The following is a description of a gene set: species: Mus musculus Mouse Gene Set: GOBP_VENTRICULAR_CARDIAC_MUSCLE_CELL_ACTION_POTENTIAL An action potential that occurs in a ventricular cardiac muscle cell., and this is the list of marker genes: Gja5, Snta1, Kcne5, Kcnj8, Nedd4l, Kcnh2, Ctnna3, Scn2b, Trpm4, Dsc2, Dsg2, Ryr2, Cacna1c, Pkp2, Kcne1, Gpd1l, Kcne3, Cav3, Rnf207, Scn5a, Bin1, Kcne4, Scn3b, Dlg1, Kcne2, Jup, Kcnd3, Kcnq1, Cav1, Dsp, Ank2